Given this list of marker genes MOCS3, RC3H2, IL18R1, RBM5, BCL10, EDEM2 (NCBI Gene Id 96814), DFFB (NCBI Gene Id 1677), UBTD2, NPC1, PRR14L, GABARAPL1, AMFR, DCTN4, CCP110, SCYL3, CDK13, FKBP1A, DAAM1, ELL2, TJP2, SLK, C16orf54, KLRD1, MFSD5, ZNF839, IKBKG, NEU1, DGCR8, C11orf24, BMF, ARHGAP35, CXCR2, SGSM3, ATMIN, FGFBP3, CDKN2B, ZBTB45, ARHGAP1, GGNBP2, FOXN3, PPP4R1 (protein phosphatase 4 regulatory subunit 1), CAMK2N2 (calcium/calmodulin dependent protein kinase II inhibitor 2), KDM2B, ZNF841, KIF3C, ARF6, ZNF217, NXT1, TMEM214, UTP4, URB2, JCAD, HAPLN3, VPS54, EHD1, PDCD7, GLDC, ZNF655, SALL2, CXCL16, GID4 (NCBI Gene Id 79018), ZBTB42, MORF4L1, ARHGAP26, NOC3L, FCRL1, CSTB, MT1E, CAPN2, ZNF280C, HMOX1, VRK3 (NCBI Gene Id 51231), RELB, MBD1, TMEM9B, TNKS2, TMEM177, BSDC1, GHR, UBXN4, TRIM44, CTNNA1, GSDME, HARS2, CHST11 (carbohydrate sulfotransferase 11), RHBDL3 (rhomboid like 3), TRIM45, ZFP91, BET1L, ATP2B1, ZNF236 (NCBI Gene Id 7776), EXO5, GPAT3, CRISP3, BRAT1, PACS2, DNAJC14, ZNF407, SEMA6D, TMEM65, NAP1L2, SLAIN2, CCDC6, ITSN2, RNF103, LITAF, ARHGEF10, PPP6C, FMNL2, TRAK1, SPART, ZNF438, AGFG1, SPECC1L, TTLL4, TAX1BP3, MARS2, SLC25A33 (solute carrier family 25 member 33), GOLGA4, SMUG1, THUMPD1, METTL4, C5orf22, DDX19A, BIRC3, CCDC66, ERCC1, ATP13A3, MDM4, UBQLN1 (NCBI Gene Id 54347), NFAT5, NAA20, LARP1, ATP8B2, MBNL2, PLA1A, SELENOI, NTF4, F2R, NHSL3, ZNF263, GOLGA5 (golgin A5), TIRAP, DYRK1A, LIMD1, DCAF12, MTRR, C8orf33, NFKBIB, ANXA2, IL23A, MED8, KDM5C, DSEL (dermatan sulfate epimerase like), ADORA2B, TANC2, ELP5, ZBTB4, MAP2K3, IMMT (NCBI Gene Id 10989), MKNK2, BACH2, SNX27, PPRC1, KMT2E (NCBI Gene Id 84147), DPM2, ANO6, BCL6, ULK1, TMEM127, PPFIBP1, TACC2, WSB2, TOR1B, PTPN3, ABTB1, ZEB1, ROCK2, CERT1, GABPB2, IL21R, IFNAR1, ARID2, TMEM115, CTDSP2, PURG, KPNA4, VPS13C, TMEM74B, ENC1, CDC42BPB, PXDC1, SLC25A46, PEX12, EPC2, BLVRB, B3GALNT2, SOCS5, RAP1B, PSMD2, here is a description of the gene set: Genes down-regulated in neutrophils: LPS versus stimulated by CSF2 and IFNG. from publication Kotz KT, Xiao W, Miller-Graziano C, Qian WJ, Russom A, Warner EA, Moldawer LL, De A, Bankey PE, Petritis BO, Camp DG 2nd, Rosenbach AE, Goverman J, Fagan SP, Brownstein BH, Irimia D, Xu W, Wilhelmy J, Mindrinos MN, Smith RD, Davis RW, Tompkins RG, Toner M, Inflammation and the Host Response to Injury Collaborative Research Program (PMID 20802500) studied in species Homo sapiens Neutrophils play critical roles in modulating the immune response. However, neutrophils have a short circulating half life, are readily stimulated in vitro, and have low levels of cellular mRNA when compared to other blood leukocyte populations. All of these factors have made it difficult to evaluate neutrophils from clinical populations for molecular and functional studies. Here we present a robust methodology for rapidly isolating neutrophils directly from whole blood and develop ‘on- chip’ processing for mRNA and protein isolation for genomics and proteomics. We validate this device with an ex vivo stimulation experiment and demonstrate the ability of the device to discriminate subtle differences in the genomic and proteomic response of peripheral blood neutrophils to direct and indirect stimulation. Lastly, we implement this tool as part of a near patient blood processing system within a multi-center clinical study of the immune response to severe trauma and burn injury and demonstrate that this technique is easy to use by nurses and technical staff yielding excellent quality and sufficient quantity of mRNA for sensitive genomic readout of the host response to injury Human Gene Set: GSE22103_LPS_VS_GMCSF_AND_IFNG_STIM_NEUTROPHIL_DN